The following is a description of a gene set: Human Gene Set: HP_STOMATOCYTOSIS Stomatocytosis species: Homo sapiens The presence of erythrocytes with a mouth-shaped (stoma) area of central pallor on peripheral blood smear., and this is the list of marker genes: RHCE, RHAG, GYPC, ABCG8, RHD, SLC2A1, GATA1, ABCG5, SPTB, EPB41, SPTA1, PIGA, SLC4A1 (solute carrier family 4 member 1 (Diego blood group)), ABCB6, GP1BA